Given this list of marker genes IFI44L, RB1, EPB41L2, CSF1R, LTC4S, RGS1, ALOX5AP, CCL3, ABI3, ENTPD1, HERPUD1, CX3CR1, HLA-DQA1, MEF2C, MAFB, PLD4, FCGR3A, CD93, FCGBP, CXCR4, ETV5, BTG2, CD9 (NCBI Gene Id 928), CD14, AXL, IL1B, VSIR, CALHM6, OLFML3, STAB1, C1QB, CCL4L2, USP53, MARCKS, IFNGR1, GPR34, SLCO2B1, YWHAH, LPAR6, HTRA1, C3, C1QC, C1QA, TREM2, GIMAP4, CCL3L3, ADAM28, A2M, CCL4, CD69, here is a description of the gene set: Human Gene Set: GAVISH_3CA_METAPROGRAM_MACROPHAGES_MAC_3 In this study, an extensive analysis was conducted to define meta-programs (MPs) capturing intra-tumor heterogeneity across a spectrum of tumor types. The approach utilized non-negative matrix factorization (NMF) to analyze each cell type separately within individual tumor samples. This involved the analysis of malignant cells, macrophages, fibroblasts, endothelial cells, epithelial cells, T-cells, and B-cells. NMF was executed with varying parameter values (K=4, 5, 6, 7, 8, 9), thereby generating 39 programs for each cell type per sample. Each NMF program was summarized by the top genes based on NMF coefficients.\nRobust MPs were then delineated for each cell type using a set of stringent criteria, including recurrence within the same tumor, similarity to programs in other tumors, and non-redundancy within a tumor. Subsequently, these robust NMF programs were clustered (per cell type) based on Jaccard similarity, leading to the identification of MPs associated with each cell type.\nTo enhance the quality of the MPs, a refinement steps were undertaken, involving the removal of MPs suspected of reflecting low-quality data (with an overrepresentation of ribosomal proteins or mitochondrial-encoded genes), single-study inclusion, or similarity to miss-annotated cell types. species: Homo sapiens Genes upregulated in subsets of cells of a given type within various tumors from publication Gavish A, Tyler M, Greenwald AC, Hoefflin R, Simkin D, Tschernichovsky R, Galili Darnell N, Somech E, Barbolin C, Antman T, Kovarsky D, Barrett T, Gonzalez Castro LN, Halder D, Chanoch-Myers R, Laffy J, Mints M, Wider A, Tal R, Spitzer A, Hara T, Raitses-Gurevich M, Stossel C, Golan T, Tirosh A, Suvà ML, Puram SV, Tirosh I (PMID 37258682)